The following is a description of a gene set: part of: Amine ligand-binding receptors Reactome Pathway: Histamine receptors Histamine is a biogenic amine involved in local immune responses, regulation of gut function and neurotransmission. It exerts its actions by binding to histamine receptors. There are four receptors in humans, H1-H4 (Hill SJ et al, 1997). species: Homo sapiens, and this is the list of marker genes: HRH2, HRH1, HRH4, HRH3